Given this list of marker genes GDA, RNF208, SLIT3, PFKFB1, TTC39C, KCTD11, TSGA10, SEC14L1, NUDCD2, KLHL40, CCNB1IP1, FBXO42, BMPR2, ITPRIPL2, CD200, ALMS1, DYNLL2, CHST11, HAX1, ZMYND15, DNAJC9, CRYAB, ACOT9, C19orf44, ANKRD26, TGFB2, RFX2, ECEL1, FMNL2, SEMA5B, PLAAT3, NEU3, IGLC7, VPS29, ALKBH2, PAGR1, TMEM208, RUNX3, EIF4ENIF1, PLSCR1, SLC25A53, FBXO30, ABCA5, EID2, RIOX1, SORBS3, BARD1, HOOK1, GDF5, TBC1D4, MESP2, TRAPPC2B, DNAJC15, IGF2BP3, ZCCHC3, METTL6, ICAM4 (intercellular adhesion molecule 4 (Landsteiner-Wiener blood group)), DLG3, RYK (receptor like tyrosine kinase), PLCB4, SCAMP1, PLAC8, PRXL2A, RPS6KA6, LGR4, AP1S1, CDC37L1, C6orf136, NLRX1, CTSV, PENK, TATDN2, TBC1D25, FBLN2, SKAP2, CBX3, CYP20A1, LTK, HMGN3, CASP3, PPP1R27, MYOM1, SWAP70, TTC9C, SART3, NEK6, SEC61B, ATP6V1C2, RABL2A, ANXA3, IGKC, ZNF239, BLTP3A, RBM19, SLC30A2, TMBIM1, BCL2A1, RIF1, ZNF516, ATF6B (NCBI Gene Id 87886), IL17A, PDLIM7 (PDZ and LIM domain 7), COPS6, PGLYRP1, PDE12, WDR18, IKZF3, IL10 (interleukin 10), CYSLTR1, TOR1AIP2, ZC2HC1A, CDCA5, HIC1, SVIP, DOCK7, PLEKHM3, MMP2, ZNF473, ARID3A, MRPL14, MEGF9, BASP1, TIGD2, PPWD1, FASLG, LAMA4, CHORDC1, DSG2, VCPIP1, GHITM, SUGT1, AOPEP, CPD (carboxypeptidase D), SHTN1, MDH2, MTERF4, TSPAN4 (NCBI Gene Id 7106), PSMG4 (proteasome assembly chaperone 4), MMD, LPIN3, MTHFS, PKIG, ZNF229, PHF10, C1S, ABHD6, FCRL1, PFN2, C11orf54, COPRS, KATNAL1, ARFGEF3, SET, ARHGAP6, CXCR3, TNFSF10, DSP, CD38, SLC16A10, RSPH1, FERD3L (NCBI Gene Id 222894), POMP (proteasome maturation protein), SAMD4A, NANOS1, CCL19, IL4, TMEM14C, TGFBR1, TNFSF11, ITPR1, HSDL2, APRT (adenine phosphoribosyltransferase), IFRD2, PLIN2 (perilipin 2), H19, FRMD4A, VARS2, HSPA4L, GABARAPL1, RNASE4, ELL2 (NCBI Gene Id 22936), SCARNA13, MED7, STARD6, CELSR2, IL15RA, ALCAM, DLGAP3, GGH (NCBI Gene Id 8836), TMEM130, KIT, CCNO, PTAR1, PERP, AHRR, SUOX, MARCKS (myristoylated alanine rich protein kinase C substrate), SNW1, MRPS31, here is a description of the gene set: from publication Hill JA, Feuerer M, Tash K, Haxhinasto S, Perez J, Melamed R, Mathis D, Benoist C (PMID 18024188) The transcription factor Foxp3 is usually considered the master regulator for the CD4+CD25+ Genes down-regulated in comparison of ActCD4TGF versus WTActCD4TGF (see Fig. 1 in the paper for details). species: Homo sapiens Human Gene Set: GSE7460_WT_VS_FOXP3_HET_ACT_WITH_TGFB_TCONV_DN